Given this list of marker genes Agt, Bdkrb2, Arrb2, Arap1, Jak2, Tyk2, Ednrb, here is a description of the gene set: Binding to a type 1 angiotensin receptor. species: Mus musculus Mouse Gene Set: GOMF_TYPE_1_ANGIOTENSIN_RECEPTOR_BINDING